The following is a description of a gene set: Mouse Gene Set: GOCC_INTRACELLULAR_CYCLIC_NUCLEOTIDE_ACTIVATED_CATION_CHANNEL_COMPLEX species: Mus musculus A protein complex that forms a transmembrane channel through which cations ions may pass in response to an intracellular cyclic nucleotide binding to the channel complex or one of its constituent parts., and this is the list of marker genes: Cnga3, Cnga2, Cnga1, Cngb3, Cnga4, Pex5l, Cngb1